Given this list of marker genes GNRHR, GPR173, TCF12, GNRHR2, MGARP, UMODL1, NR5A1, CRHBP, here is a description of the gene set: species: Homo sapiens Any process that results in a change in state or activity of a cell or an organism (in terms of movement, secretion, enzyme production, gene expression, etc.) as a result of a gonadotropin-releasing hormone stimulus. Gonadotropin-releasing hormone (GnRH) is a peptide hormone responsible for the release of follicle-stimulating hormone (FSH) and luteinizing hormone (LH) from the anterior pituitary. GnRH is synthesized and released by the hypothalamus. Human Gene Set: GOBP_RESPONSE_TO_GONADOTROPIN_RELEASING_HORMONE